Given this list of marker genes POP1, MAF, OBSL1, TRIM37, MTX2 (NCBI Gene Id 10651), GNPTAB, IDUA, SLC17A5, GUSB, PLOD3, RMRP, ADAMTSL2, VPS33A, here is a description of the gene set: Human Gene Set: HP_J_SHAPED_SELLA_TURCICA studied in species Homo sapiens A deformity of the sella turcica whereby the sella extends further anterior than normal such that the anterior clinoid process appears to overhang it, giving the appearance of the letter J on imaging of the skull. J-shaped sella turcica